Given this list of marker genes Ints8, Nhp2, Ints2, Ints3, Exosc2, Exosc3, Exosc5, Toe1, Ints5, Ints6l, Ints1, Exosc8, Tut1, Mepce, Exosc4, Nop10, Larp7-ps, Ints12, Ints4, Ints14, Usb1, Mettl16, Fto (FTO alpha-ketoglutarate dependent dioxygenase), Exosc6, Exosc7, Ints9, Exosc9, Ints11, Ints6, Larp7, Ints7, Dkc1, Mettl4, Ints10, here is a description of the gene set: Mouse Gene Set: GOBP_SNRNA_PROCESSING species: Mus musculus Any process involved in the conversion of a primary small nuclear RNA (snRNA) transcript into a mature snRNA molecule. The primary function of snRNAs is processing pre-messenger RNA in the nucleus. They have also been shown to aid in the regulation of transcription factors (7SK RNA) or RNA polymerase II (B2 RNA), and maintaining the telomeres.